The following is a description of a gene set: studied in species Mus musculus from publication Cui A, Huang T, Li S, Ma A, Pérez JL, Sander C, Keskin DB, Wu CJ, Fraenkel E, Hacohen N (PMID 38057668) Genes negatively differentially expressed in cell type: CD4+ T cell upon treatment with cytokine: IL-4 in mouse lymph nodes in vivo. Cytokines mediate cell-cell communication in the immune system and represent important therapeutic targets. A myriad of studies have highlighted their central role in immune function, yet we lack a global view of the cellular responses of each immune cell type to each cytokine. To address this gap, the authors created the Immune Dictionary, a compendium of single-cell transcriptomic profiles of more than 17 immune cell types in response to each of 86 cytokines (>1,400 cytokine-cell type combinations) in mouse lymph nodes in vivo. A cytokine-centric view of the dictionary revealed that most cytokines induce highly cell-type-specific responses. For example, the inflammatory cytokine interleukin-1β induces distinct gene programmes in almost every cell type. A cell-type-centric view of the dictionary identified more than 66 cytokine-driven cellular polarization states across immune cell types, including previously uncharacterized states such as an interleukin-18-induced polyfunctional natural killer cell state. Mouse Gene Set: CUI_T_CELL_CD4_IL4_RESPONSE_DN, and this is the list of marker genes: S100a10, Sp100, Lck, Madd, Esyt2, Rgs10, Id3, Adgre5, Cd52 (CD52 antigen), Eef2, Tent5a, Cd4, Celf2, Selenop, Tecpr1, Dgka, Zbtb20, Tcf7, Vim, Kif21b, Btg2, Stk17b (NCBI Gene Id 98267), Tdrp, Smc4, Ighm, Npc2, S1pr1, Tgfb1, Emb, Sugt1, Gmfg, Atp1b1 (ATPase, Na+/K+ transporting, beta 1 polypeptide), Ipcef1, Cd74, Il7r, Pde7a, Klf6, Laptm5 (lysosomal-associated protein transmembrane 5), Klhl24, Dapl1, Klf2, Hspa1b, Stmn1, Cd3d, Lsp1, Grap2, Junb, Hspa1a, Bin1, Fxyd5, Chd3, Ly6c1, 9930111J21Rik2, Cd3g, Gramd1a, Emp3, Crlf3, Ccl5 (NCBI Gene Id 20304), Tspo, Crip1, Tsc22d3, Zfp36l2, Itgb7, Trac, Cd28, Igkc, Neat1, Myl6, Tagln2, Ehd3, Sell, Akap13, Fos, Rhoh, Saraf, Ppp1r15a, Ddit4, Gimap3, Btg1, Pik3ip1, St8sia1, Actn1, Uqcrh, Smc6 (structural maintenance of chromosomes 6), Rasgrp2, Itpkb, Ptms, Jun, Zfp36l1